The following is a description of a gene set: Human Gene Set: HP_JUVENILE_ASEPTIC_NECROSIS species: Homo sapiens Juvenile aseptic necrosis Juvenile aseptic necrosis comprises a group of orthopedic diseases characterized by interruption of the blood supply of a bone, followed by localized bony necrosis most often of the epiphyses of bones of children or teenagers., and this is the list of marker genes: MATN3, DVL3, ACAN, ADAMTS2, DYRK1A, ACTB, COL1A1, MMP13, PHF6, ORC1, ATP7A, TRPV4, ADAMTSL2, RAD21, NEK9, TINF2, SMAD2, UFSP2, WNT5A, FGFR1, EXT1, TRPS1, TONSL, ACTG1, COL2A1, CREBBP, SRCAP, SMAD3, KRAS, FN1, EP300, SIL1, LMX1B, TREX1, COMP, UNC45A, DVL1, SLC2A10, RAB3GAP2, FZD2, SKIC3, COL1A2, COL9A2